Given this list of marker genes HBG2, RPL6, RPL7AP6, NPM1, RPL23AP42, SUMO2, MT-ND1, STMN1, H3-3B, RPL10P9, RPL10P16, HMGB1P5, RPSA, TUBB, MTND1P23, MKI67, SELENOF, HNRNPC, RPS7, RPS15A, SINHCAF, YBX1P1, ID3, TMPO, TPT1, RPL35A, RPS13P2, PPDPF, SSBP1, RPL4P4 (ribosomal protein L4 pseudogene 4), CALR, ACTB, RPL32, HMGB2, YBX1P10, RPL26P19, TUBA1B, SNRPB, ARL6IP1, RPL7, FOS, HSPA8, RPL3, NUSAP1, GAPDH, UBB, MT-ND2, PCBP2, BTF3, SRSF2, DYNLL1, RPL31, RPS23, RPLP0P6, IFITM2, HBB, RHOA, DUT, RPL5 (ribosomal protein L5), LYPD1, RPL29, ATP5F1C, SNRPD2 (small nuclear ribonucleoprotein D2 polypeptide), RPLP0 (NCBI Gene Id 6175), RPL26, MARCKSL1, RPL19, RPS7P1, MTATP6P1, MT-CYB, H4C3, SRP9, ERH, RPL7A, FKBP3, CHCHD2, RPL15P3, PPIAP22, RPS18, RAN, FTH1, RAD21, RPS25, MT-ND5, YWHAQ, CADM1 (NCBI Gene Id 337934), MACROH2A1, RPL18A (NCBI Gene Id 6142), OSTC, JUN, RPL5P34, RPL23A, ATP5PF, H2AZ1, HNRNPF, RPL15, TMSB15A, EEF1B2, RPS2P5, SNRPC, RPS13, SMC4, HBA1, RPL10P6 (ribosomal protein L10 pseudogene 6), PFN1, H1-3, MTCO1P12, ATP5MC2, SEC11A, HBG1, HBA2, ILF2, NACA, HACD3, PTTG1, CNBP, PCNA, RANBP1, PPIA, SKP1, RPS4Y1, RPSA2, NPM1P39, YBX1, TOP2A, HSPE1, here is a description of the gene set: from publication Menon R, Otto EA, Kokoruda A, Zhou J, Zhang Z, Yoon E, Chen YC, Troyanskaya O, Spence JR, Kretzler M, Cebrián C (PMID 30166318) species: Homo sapiens Human Gene Set: MENON_FETAL_KIDNEY_1_EMBRYONIC_RED_BLOOD_CELLS